Given this list of marker genes APOE, ABCG5, APOB, CYP7A1, LMNA, LDLRAP1, LDLR, ABCG8, PCSK9, here is a description of the gene set: species: Homo sapiens The presence of atheromas or atherosclerotic plaques in the aorta. Human Gene Set: HP_AORTIC_ATHEROSCLEROTIC_LESION Aortic atherosclerotic lesion